Given this list of marker genes EDNRA, RIPOR2, CFL1, RAB13 (NCBI Gene Id 89672), OCLN, CORO1B, COPA, here is a description of the gene set: studied in species Homo sapiens A process in which a protein is transported to, or maintained in, a location within a cell leading edge. Human Gene Set: GOBP_PROTEIN_LOCALIZATION_TO_CELL_LEADING_EDGE